Given this list of marker genes SPRY4, LCP1, RHOA, DOCK8, ADORA2A, SLC9A5, STX4, EPB41L3, SPRY2, PIP5K1A, AMPH, RAB34, MAPT, PDE4A, ARHGEF2 (NCBI Gene Id 9181), CIB1, AKAP5, SH3YL1, MPP2, GABRA3, GABRG1, TACR3, PDE9A, IFIT5, PTPRJ, SHISA7, ADORA1, KCNC2, CLCN3, APC2, SNTG1 (syntrophin gamma 1), GRIA1, DLC1, ITGAV, ATF4, ROBO2, EPS8, GABRG2, KCNC3, MYO1C, CLCN2, INSR, EPB41L5, GABRG3, EGFR, PSD3, PLEK2, GABRE, CD44, THEM4, OPRD1, VASP, PPP1R9B, C2CD5, FERMT2, USH2A, PSD, PIEZO1, PSD4, RIPOR2, PLCG1, MYO1D, KCNA2, HIP1R, SPATA13, PLEK, EPHA2, DAGLA, GABRA5, KCNN4, ERBB2, PLEKHO1, UNC5A, TPM1, KANK1, SHISA8, GABRA4, GABBR1, CFL1, SLC39A6 (solute carrier family 39 member 6), PLA2G4F, PACSIN1, ATP2B2, SRC, HPCA, SHISA9, GABRA6, AKT2, GABRA2, SLC1A2, PLEKHA1, CLASP2, PAK1, ITGB3, DPP4, ITGA8, BMX, PLXND1, RPS3, TRPV4, ATP6AP2, PTPRK, MYO6, PIP5K1C, CACNG8, ADGRV1, SH2D3C, RAC1, TRPV1, CDKL5, ARHGAP44, SLC12A5, MTSS2, MTMR6, AIF1, ITGB1, KCNC4, APP, CSPG4, SH3BGRL3, FGR, KCNB1 (potassium voltage-gated channel subfamily B member 1), APC, THY1, KCNC1, TESC, HCN2, EEF1A1, RASGRP2, FGD5, SGCE, JCAD, PACSIN2, MACF1, CDC42, MYO1G, ANTXR1, KSR1, WWC1, FGD2, ARF4, ITGA5, FAM107A, NF2, CORO1C, VEZT, LAMP5, AIF1L, EPS8L2, SYNE2, INPP5K, ARHGAP45, SHISA6, NCKAP1, ARHGEF4, PDPN, TLN1, CLRN2, APPL2, ABCA7, RIGI, DDN, ADAM17, GPER1, DIAPH1, HCN1, CNTNAP2, MTMR9, FAP, PKHD1L1, SPTBN1, TIRAP, GABRA1, SCIMP, FERMT1, NME1 (NME/NM23 nucleoside diphosphate kinase 1, NCBI Gene Id 7794), EPS8L1 (NCBI Gene Id 54869), PLCG2, PSD2, ADGRE2, TWF1, EPS8L3, EZR, PDXP, ANK1, here is a description of the gene set: The portion of the plasma membrane surrounding the leading edge of a motile cell. Human Gene Set: GOCC_LEADING_EDGE_MEMBRANE studied in species Homo sapiens